The following is a description of a gene set: studied in species Mus musculus from publication Motenko H, Neuhauser SB, O'Keefe M, Richardson JE (PMID 26092688) Mouse Gene Set: MP_INCREASED_HEMANGIOMA_INCIDENCE Mouse genes annotated to increased hemangioma incidence (MP:0002947) retrieved from the Mouse Genome Informatics database via MouseMine, and this is the list of marker genes: Adamts3, Xpnpep1, Trappc9, Notch1, Foxo1, Pdcd10, Iqgap2, Trp53, Rundc1, Unk, Piga, Slc20a2, Pms2, Flvcr2, Hmgn1, Stk11, Pten, Tsc1, Auts2, Hmgxb3, Tbrg1, Pth1r, Cbx6, Rint1, Tusc2, Fdxr, Rala, Fbxo4, B9d2